Given this list of marker genes DBI, RIMBP3C, RIMBP3B, RIMBP3, TSPOAP1, here is a description of the gene set: Human Gene Set: GOMF_BENZODIAZEPINE_RECEPTOR_BINDING species: Homo sapiens Binding to a peripheral benzodiazepine receptor (PBR).